Given this list of marker genes LTA4H, ST3GAL1, RBBP5, ACHE, SULT2A1, GTPBP10, TSPAN1, AFF3, THRA, ING2, SEC61A1, KAT7, NCR3, MCF2L, MAP3K10, FMO4, SMAD9, ALOX15B, ABCD2, ATM, CDC14B, EXT1, MAP3K3, CD79B, GREB1, SLC31A2, CEMIP, RGS12, GPR3, KLRA1P, TCP10L3, PSD3, CDH22, CDC42EP1, TNP1, C4BPB, PXDN, BRAF (B-Raf proto-oncogene, serine/threonine kinase), COX20, IQSEC3, SMO, PKLR, PCDH9, TFF3, GRIN1, SLC24A1, SPIB, AASS, TRAM2, LCT, MYLK, ARL4D (NCBI Gene Id 379), CCT6B, PRAMEF2, PLEKHA6, ADGRB1, EML2, IL1RL2, NKX3-2, BCL2, LEP, REST, BAMBI, SLC22A6, AURKB, CD180, SCN7A, ISLR, SCNN1A, RUFY3, VENTXP7, RRN3, GRK3, PXN, GDF15, PRPF19, PHLDA1, POLR3G, CTNND1, SELENOW, CYBB, SEC24D (NCBI Gene Id 9871), SAPCD1, MYO1B, FOXH1, ASIC2, PLP1, GPER1, SP4, CYP17A1, HAX1, FLT1, CRCP, PDLIM1, KRT81, L1CAM, GNG11, KRTAP5-9, LPAR2, MT1F, PLA2G4C, GSTA2, CLCN5, PPOX, PTGER2, PRRX1, SLC12A4, KCNJ10, DRC3, BCR, ADD2, GFAP, AP2A2, CCN5, CD70, COL13A1, CASQ2, COX17, VSTM4, SLC6A8, PPFIA3, TMOD1, TJP1 (tight junction protein 1), RANBP6, NFATC3, CDH1, ZNF80, KCNN1, KPNA1, DLK1, KCNJ5, KRT9, PRKN, FNDC3A, LFNG, PCGF3, CNTFR, IFNA16, NRXN3, ETV2, DNAH9, RAB30, RASSF9, NR1I2, LAG3, RNF185, KCNJ6, AOAH, KIF1C, KRT16, RGS4, TNN, CYP3A5, HFE, NTN3, VAMP1, PPM1E, NTF3, TIMP3, ADAM2, NEUROD2, VSNL1, FETUB, KCND1 (potassium voltage-gated channel subfamily D member 1), LSR, TOP6BL, DMD, CHAF1B, FAM53B, WDR77, PDE8A, PEX12, ITCH, COMMD4, CACNG1, GPR143, MMP19, SLC30A3, MT4, FAM234B, UHRF2, BRINP3, PART1, RHOC, CXCR2, KLHL18, DDAH1, SERPINB2, FKBP1B, DAPK2, CDKN2D, MYH7, LAMA2, ZFP69B, RCBTB2, HCG4B, FMO1, SPC25, here is a description of the gene set: Genes down-regulated in brain microglia versus spleen CD8- dendritic cells. Human Gene Set: GSE29949_MICROGLIA_BRAIN_VS_CD8_NEG_DC_SPLEEN_DN To understand the functional relationship between brain dendritic cells (brain DCs) and other myeloid cells, we compared the gene expression profile of m/chDCs to that of bone marrow monocytes, brain microglia and classical spleen CD8+ and CD8- DCs. In order to obtain enough brain DCs for mRNA extraction, we expanded brain DCs with in vivo Flt3L treatment before purification. species: Homo sapiens from publication Anandasabapathy N, Victora GD, Meredith M, Feder R, Dong B, Kluger C, Yao K, Dustin ML, Nussenzweig MC, Steinman RM, Liu K (PMID 21788405)